Given this list of marker genes PLBD1 (NCBI Gene Id 79887), LSM7, CDKN1A, LMF1, LMBR1, SETD6, ROM1, ZC3H14, NUDT16L1, PDCD6, SDHC, EXOC3, POLK, COX10, MYEF2, PCCB, TLCD3A, PRKCI, ACTG1, GRHL1, FH, TRIM5, NMNAT3, MAT2A, SSX2IP, PIWIL2, RPUSD3, ELOVL6, RASSF7, WDR83OS, RNF135, CTC1, PREB, NSUN5, PTCD2, HOMER1, GAS2, SNUPN, POLR2B, CPNE2, APPBP2, HAUS7, FAM98B, TNPO1, PCBP3, DNAJC9, KAT2A, ACADS, ECSIT, PEX3, SLC5A3, RINT1, CRNKL1, FAM241A, COPS4 (COP9 signalosome subunit 4), HSD3B7, SUMF2, TRAPPC1, MAPK1IP1L, SNAP23, NDUFA8, TPRN, MON1B, ARL16, TBCB, CCNG1, ZDHHC3, KEAP1, ZNF213, CLDN12, GNE, COPE, AGPS, PLAGL2, ZBTB1, SF3A2, DYNLRB1, TMOD1, MKLN1, R3HDM1, NDUFB5, SUPT3H, ATP5F1D (ATP synthase F1 subunit delta), RCBTB2, DPP9, DECR2, ENDOG, GNPAT, DDT, FRA10AC1, SGSM3, HSPA13, DAPK2, SF3B3, LRP8, AEBP2, TAP2, SMN1, MIB1, TNPO3, ZBTB32, ZNF24, YJU2, ZSCAN22, NAA30, ABHD5, PUS3, ABITRAM, WDR73, DPP3, SLC7A6OS (solute carrier family 7 member 6 opposite strand, NCBI Gene Id 84138), TNFAIP8L1, EXOSC5, RPRD1B, IGF2R (NCBI Gene Id 3482), HDAC6, SNRNP40, ZNG1B, LYRM1, PIAS2, ABRAXAS1, ESD, DDX19A, GSTCD, PDP2, MAP2K2, MRPL4, MBNL3, DECR1, NSMCE1, OAF, NDUFS2, TRNAU1AP, GALNT7, SEL1L, LRRC20, CDC27, NSUN6, ATP5MC2, GTPBP4, FMNL2, MTFMT, POLR2J (RNA polymerase II subunit J), USP36, CLEC11A, ZNF239, EXOSC6, PIMREG, CCNK, DHX37, UBXN4, PTK2, GLCE, CD48, NQO1, BLOC1S5 (NCBI Gene Id 63915), ZNF566, RBM10 (NCBI Gene Id 8241), STING1, LIG4, MCHR1, TMEM147, C19orf47, MIPEP, GMPPA, CHCHD3 (coiled-coil-helix-coiled-coil-helix domain containing 3), LRRC14, MTFR1L, TRIP10, C11orf54, ZNF277, XPNPEP1, TIAM1, XKR8, MED25, ORC5, TRMU, NXT2, MRPL52, PLEKHA3, ABCC4, DDX47, DNAJC10, NCOA4 (nuclear receptor coactivator 4), LRPAP1, MINPP1, ASRGL1, YES1, SRSF7, C1orf122, TNPO2, RSPRY1, WWP1, GABPA, PTBP1, MTRES1 (mitochondrial transcription rescue factor 1), RTP4, RAD23A, HGH1, ALG14, here is a description of the gene set: Genes up-regulated in CD8 T cells: naïve versus effectors at day 15 after acute infection with LCMV-Armstrong. During acute viral infections, naïve CD8+ T cells differentiate into effector CD8+ T cells and, after viral control, into memory CD8+ T cells. Memory CD8+ T cells are highly functional, proliferate rapidly upon reinfection and persist long-term without antigen. In contrast, during chronic infections, CD8+ T cells become “exhausted” and have poor effector function, express multiple inhibitory receptors, possess low proliferative capacity, and cannot persist without antigen. To compare the development of functional memory T cells with poorly functional exhausted T cells, we generated longitudinal transcriptional profiles for each. species: Homo sapiens from publication Doering TA, Crawford A, Angelosanto JM, Paley MA, Ziegler CG, Wherry EJ (PMID 23159438) Human Gene Set: GSE41867_NAIVE_VS_DAY15_LCMV_ARMSTRONG_EFFECTOR_CD8_TCELL_UP